Given this list of marker genes GDAP1, ANXA11, ANO5, HMGCR, VWA1, HSPG2, DYNC1H1, VCP, LMNA, PIGN, RYR1, MYH7, JAG2, HEXB, GNE, MFN2, RRM2B, COQ7, TNNT1, SYNE2, SPG11, CRYAB, MB, CHCHD10, ATP7B, FLNC, DNM2, BICD2, VMA21, COL12A1, HNRNPA2B1, POPDC3, EMD, CRPPA, DYSF, MTMR14, SNUPN, TWNK, COL6A3, SBF2, MLIP (NCBI Gene Id 90523), TMEM43, COL6A2, HMBS, PHKA1, SLC25A4, SMPX, REEP1, SPTAN1, POGLUT1, TCAP, MYF6, SORD, HNRNPA1, NEFL (neurofilament light chain), TRIM32, TTN, SECISBP2, COL6A1, DMXL2, SYNE1, RTN2, FHL1, LAMA2 (NCBI Gene Id 3908), SMN1, DMD, CPOX, ADSS1, MORC2, SCN4A, POLG, LIPE, POLG2, BIN1, here is a description of the gene set: Proximal muscle weakness in lower limbs Human Gene Set: HP_PROXIMAL_MUSCLE_WEAKNESS_IN_LOWER_LIMBS A lack of strength of the proximal muscles of the legs. species: Homo sapiens